The following is a description of a gene set: studied in species Homo sapiens Genes up-regulated in periperal blood monocytes (PBMC) from kidney transplant recipients: tolerant versus immunosuppressive therapy. Human Gene Set: GSE22229_UNTREATED_VS_IMMUNOSUPP_THERAPY_RENAL_TRANSPLANT_PATIENT_PBMC_UP In this study, investigators recruited the largest reported cohort of tolerant kidney transplant recipients who maintained their graft after ceasing to take their immunosuppression drug, and compared this cohort to subjects with stable allograft function while on immunosuppression and healthy non transplated, controls. Using gene expression studies, they identified genetic markers that are strong candidates for predicting kidney transplant candidates who may benefit from minimization or withdrawl of immunosuppression. Microarrays were used to detect expressed gene profiles of whole-blood total RNA from subjects in the tolerant, standard immunotherapy and healthy control participants from publication Newell KA, Asare A, Kirk AD, Gisler TD, Bourcier K, Suthanthiran M, Burlingham WJ, Marks WH, Sanz I, Lechler RI, Hernandez-Fuentes MP, Turka LA, Seyfert-Margolis VL, Immune Tolerance Network ST507 Study Group (PMID 20501946), and this is the list of marker genes: TEAD1, URGCP, NR1H4, DNAH8, MPPED2, TMEM170A, SPRED1, NIPAL3, ADCY7, TXNRD3, OTC, WIZ, GPR161, GFRA2, PLSCR4, ARV1 (ARV1 homolog, fatty acid homeostasis modulator), ZNF29P, ALX1, TBC1D24, CSGALNACT1, H2BC13, USP54, BCL11A, GIGYF1, PRKCH, CBFA2T2, CCL28, F12, TSC1, SMIM6, HLA-B, CCRL2, RBM4B, TMT1A, NUCB1, ATP12A, TRIP6, CRIM1, SCGB1A1, ALOX15 (arachidonate 15-lipoxygenase), RGS12, PML, CRIPTO, ST3GAL1, DSC3, ISG20, SIPA1L1, PAK6, EZR, GARNL3, TLX2, KLHDC8B, OLFML2A, LIF, BDKRB1, PCDHB6, KDM5B, AGO1, FOXO3, MOB3C, TEX29 (NCBI Gene Id 404761), KMT2C, INPP5E, CCDC171, NKX6-2, GRM3, FHL1, CAMSAP1, TMEM40, PARD6B, TSPAN13, REC8, GFOD2, NAP1L3, GNB4 (G protein subunit beta 4), NLGN1, MKRN1, TXNIP, DKKL1 (NCBI Gene Id 27120), DYDC1, AXL, PPP1R15A, CXCL16, MARCHF3, DOCK5, PADI1, STK39 (NCBI Gene Id 27347), PDZK1IP1, CRYGS, SELENOW, KCNN4, LRSAM1, CTTN, CAP2, H2AC25, MAP7, CYB5A, NMT2, IL18BP, COMT, FCAMR, RNASE1, NOTCH2, PABPC5, MRPL52, CDH7, CA5B, TRAPPC12, LHPP, FAM110B, CLCN2, GUCA1A, ERP27, KCNQ1, UNC5CL, SMAP2, CHST11, CADM1, SMO, DDO, PLAAT3, GSTT1, PITPNC1, PRKCQ, IL27RA, C6orf141, DNAH17, GAB1, CEACAM20, SERPINB9, SYN3, OSBPL6, RASL11A, IDO1 (NCBI Gene Id 3620), IMPDH2, NEK5, LYRM9, SPRED2, PHACTR4, HDAC3, SH3YL1, SNHG8, POU5F1, C3orf33, SHC3, LGALS3BP, LIPA, CCNB3, DLX2, SORBS1, SMAD9, BSDC1, THEM4, GPATCH8, CSPG5, KRIT1, SAMD9L, ZBTB45, SPATA31F1, STAC, DMWD, TENM2, FAM171A2, CCL19, LRP2, AMER1, KIAA1958, ARIH2, DMRT3, TCEAL9, MIDEAS, SYT6, ZNF541, DYNLT3 (NCBI Gene Id 6990), TMCO4, SLC66A2 (NCBI Gene Id 80148), SYT13, EXTL3, RAB42, DNAJB13, PRSS22, TPH2, CD160 (NCBI Gene Id 11126), ARHGAP6, CNTNAP2, ZKSCAN1, ATP6V0A2 (NCBI Gene Id 7854), LIPT2, FAM184A, STXBP1, EGR1, SLC2A3, FOXJ2, DTX3 (NCBI Gene Id 196403), PABIR1 (PP2A Aalpha (PPP2R1A) and B55A (PPP2R2A) interacting phosphatase regulator 1), QPRT, PARD3, AGPAT4, FNTA, BAHCC1